The following is a description of a gene set: One hallmark of ECM proteins is their domain-based structure. Exploiting this characteristic, we established a list of diagnostic InterPro domains commonly found in ECM proteins. We know that some of the domains used to select positively for ECM proteins are also found in transmembrane receptors and proteins involved in cell adhesion (growth factor receptors, integrins, etc) that do not belong to the ECM. These families of proteins also display a subset of specific domains and transmembrane domains incompatible with definition as Genes encoding secreted soluble factors studied in species Mus musculus Mouse Gene Set: NABA_SECRETED_FACTORS from publication Naba A, Clauser KR, Hoersch S, Liu H, Carr SA, Hynes RO (PMID 22159717), and this is the list of marker genes: Pik3ip1, Pf4, Ifnk, Ifna14, Bmp2, Hbegf, Epgn, Cbln1, Cbln4, Ccl27a, Pdgfa, Hgf, Cxcl5 (C-X-C motif chemokine ligand 5), Il17f, Tchh, Wnt4, Cxcl3, Nrtn, Tgfb2, Gdf10, Hhip, Tnfsf10, Fgf13, Prl2a1, Mdk, Cxcl11, Megf6, Ins2, Gm13283, Wnt5a, Il13, Gm13276, Il11, Il4, Ccbe1, Il3, Prl7a2, Il15, Lep, Bmp8a, Prl8a8, Prl8a9, Wnt7a, Flg2, Vegfd, Il36g, Hrnr, Prl2c5, Epo, S100a9, Fgf16, Angptl7 (angiopoietin-like 7), Brinp3, Ebi3, Cbln2, S100a2, Chrd, Il5, Igf2, Tnfsf12, Flt3l, Amh, Gm5849, Fgf7, Il12a, Il22, Clcf1, Prl3d2, Brinp2, Xcl1, Tgfa, Bmp5, S100a8, Ctf2, Tnfsf8, Tnf, Ifna5, Ccl12, S100b, Tgfb3, Egfl6, S100z, Megf11, Prl6a1, Gm13288, Gdf2, Angpt1 (NCBI Gene Id 68823), Wnt10b, Angpt4, Prl3b1, Ccl6, Megf10, Tnfsfm13, Il10, Wnt7b, Ctf1, Fgf5, Il6, Kitl, Egf, Cxcl15, Vegfc, Lif, Csf1, Ppbp, Ifna2, S100a14, Bmp10, Wnt8a, Csf2, Lefty1, Hcfc2, Ccl1, Wfikkn2, Gdf1, Il1a, Scube2, Scube1 (NCBI Gene Id 64706), Sfrp5, Il18, Ccl20, Gm13272, Tnfsf13, Egfl8, Ifng, Scube3, Ccl27al, Gm13277, Nrg1, Ifnab, Cntf, Gdf11, Prl2c1, Gdf9, Ifne, Fgf18, Hcfc1, Thpo (NCBI Gene Id 21832), Ifna6, Pdgfd, Fgf4, Wfikkn1, Ifna15, Ihh, S100a1 (S100 calcium binding protein A1), Wnt5b, Tnfsf9, Angpt2, Crlf3, Wnt9b, Prl5a1, S100a5, Vwc2, Ccl19, Fgf21, Fgf11, Inha, Il36a, Cx3cl1, Sfrp1, Angptl2, Ntf5, Gdnf, Cxcl1 (C-X-C motif chemokine ligand 1), Tnfsf18 (tumor necrosis factor (ligand) superfamily, member 18), Gm13279, Fgf12, Angptl6, Vegfb, Pgf, Fstl3, Mstn, Wnt10a, Bmp7, Vwc2l, Ifna9, Prl, C1qtnf12, Eda, Wnt3a (wingless-type MMTV integration site family, member 3A), Mst1, Artn, Ccl9, Gh, Egfl7, Wnt6 (wingless-type MMTV integration site family, member 6), Prl3c1, Tchhl1, Ifna7, Ccl17 (C-C motif chemokine ligand 17), Areg, Megf8, Gm13289, Prl7a1, Crnn, Tnfsf14, S100a13, Wnt11, Prl8a6, Fgf22 (fibroblast growth factor 22), Fgf3, Ifna16, Pdgfb (NCBI Gene Id 18591), Insl6 (NCBI Gene Id 27356), Prl3a1, Il34, Ltb, Fgf17, Dhh, Gm13290, Gm13275, Wnt8b, Ccl25, Il9, Cxcl13, Prl7b1, Angptl1, Wnt16, Ifna11, Ifna1, Gm13278, Cxcl2, Il17a, Fgf20, Gm13271, Il12b, Nrg2, Bmp4, Fstl1, Pspn, Cxcl9, Ccl7, Fgf23, Ism2, Ereg, Ifnz, Megf9, Ccl4, Prl3d3, Gdf6, Fgf6, Ccl24, Wnt3, S100a11, Ccl3, Ngf, Shh, Rptn, Csf3, Ifnb1, Prl2c3 (prolactin family 2, subfamily c, member 3), Il17d, Ifna13, Ccl11, S100a3, Gm13287, Ccl5, Il16, Bmp15, Gdf7, Cxcl12, Fst, Wnt1, Fgf8 (NCBI Gene Id 14179), Cfc1, Ifna4, Fgf14, Ins1, Cxcl14, Gdf3, Lta, Ccl22, Prl2c2, Nrg3, Wif1, Angptl4, Bdnf, Ccl2, Frzb, Inhbe, Ccl21b, Il19, Fgf10, Il17b, Il7, Insl3, Il1b, Cbln3, Fgfbp1, Fgf9, Chrdl1, Hgfac, Fgfbp3, Igf1, Bmp3, Prl4a1, S100a16, Pdgfc, Tpo, Ccl28, Ntf3, Flg, Crhbp, Fgf2, Ism1, Il25, S100a6, Il36b (interleukin 36B), Wnt2, Prl2b1, Ccl21a, Il24, Tnfsf15, Tnfsf11, Il2, Vegfa, Il36rn, Fgf15, Nrg4, Prl3d1, Cxcl10, Il23a, Btc, Wnt2b, Gdf5, Sfrp2, Il17c, Fasl, Tgfb1, Il1f10, Chrdl2, Inhbb, S100a7a, Prl7d1, Inhbc, Osm, Prl8a2, Crlf1, Cripto, Wnt9a, Erfe, S100a4, Tnfsf13b, Gm13285, S100g, Angptl3, Bmp6, Inhba, Prl8a1, Fgf1, Lefty2, S100a10, Prl7c1, Tnfsf4, Il20, Ifna12, Ccl26, Insl5, Ptn, Bmp8b, Nodal, Ccl8, Il1rn, Gdf15, Sfrp4